The following is a description of a gene set: species: Mus musculus Signaling by the B Cell Receptor (BCR) Mouse Gene Set: REACTOME_SIGNALING_BY_THE_B_CELL_RECEPTOR_BCR, and this is the list of marker genes: Cd79b, Adrm1, Ighv3-8, Ubb, Lyn, Psmd1, Ighv5-6, Igkv1-131, Igkv8-21, Nfatc1, Ighv7-2, Psmd2, Calm3, Psmb5, Calm2, Psmd8, Psmb4, Igkv1-88, Ighv8-9, Psmd12, Psma2, Trpc1, Pik3r1, Nfkb1, Igkv2-109, Stim1, Nck1, Psmc5, Ighv5-2, Psmc3, Igkv1-122, Cul1, Ighv6-5, Nfatc3, Cd79a, Btk, Igkv20-101-2, Igkv2-112, Itpr3, Ighv8-6, Psmd3, Ighv7-3, Psmc6, Ighv5-9, Ighv5-15, Calm1, Psmc2, Igkv1-117, Psmd14, Igkv1-99, Plcg2, Ighv5-17, Pik3cd, Sh3kbp1, Igkv16-104, Rel, Cd22, Fkbp1a, Nfatc2, Iglc1, Igkv1-110, Rela, Potefam3c, Ighv7-4, Psma5, Igkv17-121, Psmb7, Dapp1, Ighv8-11, Uba52rt, Ighv8-13, Ighv6-3, Psma4, Psma3, Ikbkg, Psmd11, Ighv8-8, Ighv8-4, Card11, Ppp3cb, Ppp3ca, Igkv1-133, Ighv16-1, Iglc2, Psmd13, Rps27a, Ighv6-4, Ighv5-16, Igll1, Syk, Ighd, Skp1, Ighv3-1, Nfkbia, Ighv8-5, Pik3ap1, Ptpn6, Kras, Psmc4, Rasgrp3, Rasgrp1, Itpr2, Malt1 (MALT1 paracaspase), Igkv18-36, Ighv12-3, Igkv11-125, Psma6, Ighv8-12, Prkcb, Ighv8-2, Fbxw11, Psmb6, Igkv2-137, Ighv13-2, Psmd7, Potefam3d, Psmd6, Vav1, Ppp3r1, Ighv5-9-1, Ighv3-3, Psmb1, Igkv1-35, Ighv5-4, Psma7, Psmc1, Ighv3-5, Sos1, Hras, Nfkbib, Cd19, Ikbkb, Bcl10, Psma1, Grb2, Psmb3, Igkv15-103, Chuk, Ighv3-6, Itpr1, Blnk, Igkv1-135, Ubc, Uba52, Ighv3-4, Ighv5-12, Ighv6-7, Igkv1-132, Psmb2, Ighv6-6, Ighv5-12-4 (NCBI Gene Id 630837)